The following is a description of a gene set: Human Gene Set: GOBP_TELOMERE_MAINTENANCE_VIA_SEMI_CONSERVATIVE_REPLICATION The process in which telomeric DNA is synthesized semi-conservatively by the conventional replication machinery and telomeric accessory factors as part of cell cycle DNA replication. studied in species Homo sapiens, and this is the list of marker genes: UPF1, TERF1, RTEL1, TERF2, BLM, DNA2, PCNA, WRN, FEN1